Given this list of marker genes Zdhhc2, Zdhhc6, Zdhhc20, Zdhhc3, Zdhhc17, Zdhhc7, Zdhhc15, here is a description of the gene set: Mouse Gene Set: GOMF_PROTEIN_CYSTEINE_S_STEAROYLTRANSFERASE_ACTIVITY studied in species Mus musculus Catalysis of the transfer of a stearoyl (systematic name, octadecanoyl) group to a sulfur atom on the cysteine of a protein molecule, in the reaction: octadecanoyl-CoA + L-cysteinyl- = CoA + S-octadecanoyl-L-cysteinyl-.